Given this list of marker genes TYROBP, NFKBIA, ICAM1, MAFB, IL1R2, CD38, MFNG, FANCG, HDAC1, LYN (LYN proto-oncogene, Src family tyrosine kinase), LMO1, IL2RA, CHEK1 (checkpoint kinase 1), STAT1, SNAI1, IL21R, CD80, SPN, SOX4, CCNB2, SPI1, NFKBIB, MAPK3, CCNB1, IL15, FAS, FASLG, TNFRSF13C, PSEN1, ITGAM, WNT3A, GNAS, SMAD7, H2AX, NBN (nibrin), CDK2, MAFK, here is a description of the gene set: species: Mus musculus Aside from Myc-activating translocations characteristic of plasmacytomas (PCT), little is known about genetic factors and signaling pathways responsible for the development of spontaneous B-cell lineage lymphomas of mice. Here, we characterized the transcriptional profiles of PCT, centroblastic diffuse large B-cell lymphomas (CBL), and high-grade splenic marginal zone B-cell lymphoma (MZL++) using high-throughput quantitative reverse transcription-PCR. Expression profiles of CBL and MZL++ were strikingly similar and quite unlike that of PCT. Among the genes expressed at significantly higher levels by PCT were a number involved in NOTCH signaling, a finding supported by gene set enrichment analyses of microarray data. To investigate the importance of this pathway, NOTCH signaling was blocked in PCT cell lines by treatment with a gamma-secretase inhibitor (GSI) or transduction of a dominant-negative mutant of MAML1. These treatments resulted in reduced expression of NOTCH transcriptional targets in association with impaired proliferation and increased apoptosis. GSI treatment of transformed plasma cells in a primary PCT also induced apoptosis. These results integrate NOTCH activation with oncogenic signaling pathways downstream of translocated Myc in the pathogenesis of mouse PCT, two signaling pathways also implicated in development of human multiple myeloma and T-cell lymphoblastic lymphoma. Human Gene Set: SHIN_B_CELL_LYMPHOMA_CLUSTER_8 from publication Shin DM, Shaffer DJ, Wang H, Roopenian DC, Morse HC 3rd (PMID 19010892) Cluster 8 of genes distinguishing among different B lymphocyte neoplasms.